Given this list of marker genes Tor1aip2, Zfp462, Adamts12, Ppie, Slc8a1, Abcc9, Mex3c, Bmpr2, Ccdc85a, Psip1, Lurap1l, Hycc2, Tex36, Rab14, Dcun1d4, Efemp1, Rab40b, Ube2d3, Trmt11, Efhd1, Ifitm10, Atp6v1b2, Prph, Ppcdc, Mme, Ppargc1a, Tenm3, Flcn, Nin, Oscar, Hectd2, Pigm, Errfi1, Kctd12, Chfr, Erich5, Nkrf, Galnt2, Zic3, Abi2, Or6d12, Marcksl1, Esrrg, Tet2, Exoc6b, Prtg, Mgat4a, Luc7l3, Pabir2, Gpr75, Stx5a, Hecw1, Skida1, Bmal2, Vim, Afdn, Rarres1, Elmod1, Ttc9c, Satb1, Taf7, Ubqln2, Mfsd4b2, Cyfip2, Rhebl1, Syncrip, Etf1, Pitx2, G3bp1, Gabra2, Slc4a10, Prps1l3, Phf20l1, Ppip5k2, Gm5820, Edf1, Nts, Htr1f, Rpe, Fryl, Ak7, Myef2, Inpp4b, Creb5, Fgf13, Gtf3c3, Toe1, Arid2, Rrn3 (NCBI Gene Id 98048), Rab18, Mapk1, Afp, Zfp592, Sertad2, Zbtb11 (NCBI Gene Id 271377), Cxxc5, Hnrnpa0, Megf11, Tbl1xr1, Meox2, Slc31a2, Wdr26 (WD repeat domain 26), here is a description of the gene set: Mouse Gene Set: MIR_6402 species: Mus musculus Genes predicted to be targets of miRBase v22 microRNA mmu_miR_6402 in miRDB v6.0 with MirTarget v4 prediction scores > 80 (high confidence targets). from publication Chen Y, Wang X (PMID 31504780)